Given this list of marker genes PUF60, MSMB, RPN2, PLA2G2A, SRSF1, GRIN1, SLC9A6, MFN2, RARS1, CPVL, PYROXD1, DNAH7, CADM4, GMPS, MLLT3, EFEMP1, APOBEC3C, FBXW11, RETREG3, ZNF146, PRRC2B, ZBTB25, KAT6A, ARPC5, USP1, RNASE1, LBX1, PGAM2 (NCBI Gene Id 5224), XRCC5, TOR1AIP1, FGF1, XCL1, LDHB, KNTC1, LSM6, CILK1, HNMT, ZNF623, UBR2, KDM4A, MEA1, OVOL2, STAB1, MDH2, SSRP1, CTNNB1, AHCTF1, MSH2, ZNF629, NARS1, SUPT4H1, ATXN3, ZNF212, KIAA0753, CEP170, ITGAL, SLC46A3, CNPY3, SACM1L, RIN2, FUT1, PPIH, CDC7, AKAP1, EIF4G2, SLC43A1, ADCY7, PRCP, CRYAA, SLC4A7, PTPN18, FCGR3A, COX20, GGA2 (NCBI Gene Id 23062), TAF15, COG2, EPS15, GTF2H5, PPIF, CREB1, MISP (mitotic spindle positioning), PSIP1, SNRPE, GPX3, SPTLC1, SRRM1, PTPN9, TNP1 (transition protein 1), ZNF124, ARHGEF16 (NCBI Gene Id 27237), ATOSB, RHOA, TACR1, WSCD1, YES1, PYGL, COMT, TBKBP1, AIF1, FGF6, DGAT1, PRDX2, CD163, NHLH1, GLOD4, OAT, BRINP1, GIP, ABCB1, KLHL9, ZFC3H1, MBNL1, GML, UTP18, MAP3K14, MYOZ2, PATZ1, SLC26A3, UBXN1, XRCC2, MRE11, JUN, DDC, GLMN, ITSN1, PLEKHO2, CCNB1, SET, SYN3, PKP4 (plakophilin 4), EI24, ABL1, PRKAG1, STIM1, ACP1, SDHB, SNRPD3, GPR15, IRF5, NFASC, CAPZA1, NCOA6, GABRA2, CD302, TXLNA, PRDX3, SEPTIN6, ELMO1, ATP5PD, LRBA, SOD3, LSM4, ABCB7, LRRC37A2, MTMR6, NRF1, DDX3X, COPS3, PTPN22 (NCBI Gene Id 5779), ZNF292, POP4, PIAS4, STS, MIEF1, NECAB3 (N-terminal EF-hand calcium binding protein 3), DRG1, LAMTOR5, RCHY1, RSL1D1, FARP1, COQ2, TTF1, MOB4, NREP, NMU, TAB1, GDI2, PRODH, PDHB, PAK1, VPS39, KRT34, PTPRN2, PGRMC1, FABP6, DOK5, SORD, AGTR2, MAGEA4, EIF3D, EXPH5, LMO2, RHBDD3, CTNNBIP1, PPBPP2, CUL4B (cullin 4B), METAP1, RUSC1, BAAT (bile acid-CoA:amino acid N-acyltransferase), GAPVD1, here is a description of the gene set: Monocyte-derived dendritic cells (DC) and macrophages (MΦ) generated in vitro from the same individual blood donors were exposed to five different pathogens, and gene expression profiles were assessed by microarray analysis. Responses to Mycobacterium tuberculosis and to phylogenetically distinct protozoan (Leishmania major, L. donovani, Toxoplasma gondii) and helminth (Brugia malayi) parasites were examined, each of which produces chronic infections in humans yet vary considerably in the nature of the immune responses they trigger. Genes up-regulated in comparison of macrophages exposed to L. donovani versus macrophages exposed to L. major. from publication Chaussabel D, Semnani RT, McDowell MA, Sacks D, Sher A, Nutman TB (PMID 12663451) Human Gene Set: GSE360_L_DONOVANI_VS_L_MAJOR_MAC_UP studied in species Homo sapiens